Given this list of marker genes Igsf11, Gpm6a, Adcy8, Elavl2, Calb2, Slc17a7, Plcb4, Grid2, Pclo, Lrrtm1, Afdn, Cacng3, Nlgn2, Slc16a3, Adgrb3, Srpx2, Cyfip1, Grm4, Homer1, Git1, P2rx6, Ntrk2 (NCBI Gene Id 77471), Gria1, Stxbp1, Itga3, Nlgn1, Itgb1, Cbln1, Unc13a, Scn8a, Neto1, Syndig1, Snap91, Cbln3, Fgfr2, Picalm, Nrxn1, Mgll, Nlgn4l, Slc1a6, Nlgn3, Shank1, Grin1, Gnb5, Akap5, Kcnh1, Pfn1, Atp2b2, Ywhah, Kcnj6, Slc17a8, Gnao1, C1ql2, C1ql1, Syp, Susd4, Met, Grin2b, Plxna4, Elfn1 (leucine rich repeat and fibronectin type III, extracellular 1), Syt1, Gria3, Cadps2, Rab3gap1, Grn, Synj1, Ppfia4, Ogt, Sema3a, Cntn6, Slc6a9, Actr3, Grid2ip, Palld, Chd4, Sort1, Slc16a7, Cadm3, Lrrc4, Shisa6, Pde4b, Bsn, Ctnna2, Slc17a6, Cntnap2, Dgki, Shank3, Sptbn2 (spectrin beta, non-erythrocytic 2), Ntm, Rapgef4, Atp2b3, Unc13c, Dlg4, Baiap2, Lrrtm2, Tmem240, Kcnj9, Ptprf, Grin2a, Plxnc1, Shisa7, Dbn1, Syt11, Kcnj3, Ppp3r1, here is a description of the gene set: A synapse in which an action potential in the presynaptic cell increases the probability of an action potential occurring in the postsynaptic cell. species: Mus musculus Mouse Gene Set: GOCC_EXCITATORY_SYNAPSE